Given this list of marker genes Slc41a1, Slc30a10, Slc41a2, Slc24a1, Slc11a2, Slc39a6, Slc30a8, Slc39a2, Slc39a7, Slc24a3, Slc9a6, Slc9a5, Slc24a5, Slc9a1, Slc39a14, Slc8b1, Slc39a4, Calm1, Slc24a2, Slc11a1, Slc30a5, here is a description of the gene set: This event has been computationally inferred from an event that has been demonstrated in another species.<p>The inference is based on the homology mapping from PANTHER. Briefly, reactions for which all involved PhysicalEntities (in input, output and catalyst) have a mapped orthologue/paralogue (for complexes at least 75% of components must have a mapping) are inferred to the other species. part of: SLC-mediated transmembrane transport species: Mus musculus electronically inferred by orthology from the curated human pathway Reactome Pathway: Metal ion SLC transporters